The following is a description of a gene set: Genes up-regulated in peripheral blood mononuclear cell females vs males in adults (50-74) (females) after exposure to Fluarix, time point 0D, 3DY, 28D. Comment: Caucasian adults (50-74); See Suppl Table 6 for full DE gene list, time point 0D, 3DY, 28D combined (identical signatures) from publication Voigt EA, Ovsyannikova IG, Kennedy RB, Grill DE, Goergen KM, Schaid DJ, Poland GA (PMID 30873150) species: Homo sapiens Human Gene Set: VOIGT_PBMC_FLUARIX_AGE_50_74YO_FEMALES_VS_MALES_0DY_TO_28D_UP <b>Background:</b> Sex differences in immune responses to influenza vaccine may impact efficacy across populations. <b>Methods:</b> In a cohort of 138 older adults (50-74 years old), we measured influenza A/H1N1 antibody titers, B-cell ELISPOT response, PBMC transcriptomics, and PBMC cell compositions at 0, 3, and 28 days post-immunization with the 2010/11 seasonal inactivated influenza vaccine. <b>Results:</b> We identified higher B-cell ELISPOT responses in females than males. Potential mechanisms for sex effects were identified in four gene clusters related to T, NK, and B cells. Mediation analysis indicated that sex-dependent expression in T and NK cell genes can be partially attributed to higher CD4+ T cell and lower NK cell fractions in females. We identified strong sex effects in 135 B cell genes whose expression correlates with ELISPOT measures, and found that cell subset differences did not explain the effect of sex on these genes' expression. Post-vaccination expression of these genes, however, mediated 41% of the sex effect on ELISPOT responses. <b>Conclusions:</b> These results improve our understanding of sexual dimorphism in immunity and influenza vaccine response., and this is the list of marker genes: STAP1, FCRL5, NIBAN3, RALGPS2 (Ral GEF with PH domain and SH3 binding motif 2), KHDRBS2, SPIB, CD22, CD40, TSPAN13, CDCA7L, DPF3, TCL6, PTPRK, BLNK, CD19, FCRL2, ADD2, MOXD1, NXPH4, PAWR